The following is a description of a gene set: Human Gene Set: GOMF_3_5_DNA_HELICASE_ACTIVITY Unwinding a DNA helix in the direction 5' to 3', driven by ATP hydrolysis. studied in species Homo sapiens, and this is the list of marker genes: RECQL5, FANCM, MCM6, ERCC3, ASCC3, RECQL4, MCM5, BLM, FBH1, WRN, MCM2, RECQL, HELQ, NAV2, DHX9